Given this list of marker genes Orc4, Mcm2, Mcm8, Pola1, Pole2, Mcm4, Rpa1, Pole, Cdc45 (NCBI Gene Id 12544), Mcm7, Orc3, Cdc6, Orc1, Dbf4, Cdc7, Pola2, Prim1, Orc5, Gmnn, here is a description of the gene set: Reactome Pathway: Activation of the pre-replicative complex studied in species Mus musculus electronically inferred by orthology from the curated human pathway part of: DNA Replication Pre-Initiation; G1/S Transition This event has been computationally inferred from an event that has been demonstrated in another species.<p>The inference is based on the homology mapping from PANTHER. Briefly, reactions for which all involved PhysicalEntities (in input, output and catalyst) have a mapped orthologue/paralogue (for complexes at least 75% of components must have a mapping) are inferred to the other species.